Given this list of marker genes TOMM7, PEX5, CETN1, PRKAG2, PGAM5, TUBB4A, TOMM20, EPAS1, TOMM6, UBA52, MAP1LC3B, PRKAG3, MFN2, PRKAA2, ARL13B, CFTR, TUBA1A, SQSTM1, VDAC2, TUBA4A, DYNC1I1, TUBA1B, UBE2N, UBB, PLIN3, PLIN2, TUBA8, UBC, TUBB8B, DYNLL2, TUBB8, DYNLL1, PRKN, TOMM22, MTERF3, DYNC1LI2, TUBB2A, RPS27A, MAP1LC3A, PARK7, CSNK2A1, HSF1, CSNK2B, HDAC6, TUBB6, DYNC1LI1, TOMM70 (translocase of outer mitochondrial membrane 70), ATG9A, TUBB4B, VCP, TUBB2B, UBE2L3 (ubiquitin conjugating enzyme E2 L3), SRC, NBR1, PINK1, HSP90AA1, IFT88, ULK1, CSNK2A2, PRKAB1, UBE2D2, ATG5, TUBA3C, VIM, VDAC1, VDAC3, DYNC1I2, FUNDC1, TUBB3, DYNC1H1, PCNT, TUBA3E, TOMM40, PRKAG1, HSPA8, TBK1, TUBAL3, USP30, MFN1, PRKAB2, TUBA3D (tubulin alpha 3d), OPTN, ATM, TUBB1, UBE2V1, TUBA1C, TOMM5, ATG12, UBE2D3, TUBA4B, here is a description of the gene set: species: Homo sapiens Human Gene Set: REACTOME_SELECTIVE_AUTOPHAGY Selective autophagy